Given this list of marker genes TFB2M, RNASEL, EIF4A3, RPS17, RPP40, RPL27, BMS1, EXOSC1, RPS24, NVL, MRM3, NPM3 (NCBI Gene Id 63295), RPP30, EXOSC6, PES1, RPS7, RPS6, UTP4, RBM34, GAR1, DROSHA, RPL11, DCAF13, IMP4, MPHOSPH10, NUDT16, DKC1, RPS25, NOC4L, POP4, PPAN, RPUSD4, TBL3, LAS1L, NOP2, NSA2, MRTO4, RPS8, FTSJ3 (NCBI Gene Id 54803), MPHOSPH6, DDX54, METTL5, DIMT1, METTL15, EIF6, NSUN3, NOL9, RPL7A, RPP25, SRFBP1, RPL35, REXO1, NOP58, GTF2H5, RCL1, METTL18, MAK16, ESF1, RPS14, RPP38, FBLL1, POP7, PIH1D1, SART1, PRKDC, NOP56, NOL10 (NCBI Gene Id 80085), RIOK2, TSR3, ERI1, NOP53, WDR43, GEMIN4, RIOK1, SPOUT1, WDR75, URB1, TRMT2B, UTP14A, DDX27, MRM1, SLX9, PIH1D2, WDR74, FRG1, EMG1, RPL7 (ribosomal protein L7), SUV39H1, TSR2 (TSR2 ribosome maturation factor), LYAR, RRP9, ZNHIT6, REXO5, WDR3, TRMT61B, RRP1B, DDX47, UTP3, PWP2, WDR12, XRN2, NOL7, DDX49 (NCBI Gene Id 54701), WDR18, EXOSC5, MTREX, EXOSC7, RRP36, UTP15, EXOSC2, NGDN, C1D, SDE2, BUD23 (NCBI Gene Id 84118), RRP1, EXOSC8, METTL25B, PAK1IP1, EXOSC10, RPUSD2, TFB1M, BRIX1, UTP25, DIS3, UTP18, RPS28, PWP1, KAT2B, KRI1, DDX17, UTP14C, RPS21, WDR36, ZCCHC4, DDX10, DDX51, METTL16, NOL6, MTERF4, DDX56, RRS1, UTP6, RRP8, NSUN4, RPS16, RRP7A, METTL15P1, UTP11, PDCD11, RRP7BP, DDX18, PA2G4, EBNA1BP2, USP36, RIOK3, IMP3, POP5, ABT1, RPUSD1, SNU13, RPF1, DDX21, EXOSC3, WDR46 (NCBI Gene Id 9277), EXOSC4, RPF2, TENT4B, CHD7, NOL8, NOP10, KRR1, NAF1, YTHDF2, RPL5, RPS19, RPL7L1, AK6, FBL, FCF1, CDKN2A, ISG20, RPL35A, UTP23, SBDS, WBP11, NAT10, PELP1, REXO1L1P, SIRT7, NOLC1, NOP9, DHX37, NOB1, WDR55, HEATR1, RPL26, NHP2, LSM6, RRP15, YBEY, EXOSC9, MYG1, BOP1, RPL14, RPS15, ERCC2, MRM2, RPS27, UTP20, FDXACB1, NSUN5, NOL11, PIN4, NOP14, TSR1 (NCBI Gene Id 55720), REXO4, ZNHIT3, DDX52, GTPBP4, BYSL, TRMT112, RBFA, here is a description of the gene set: Human Gene Set: GOBP_RRNA_PROCESSING species: Homo sapiens Any process involved in the conversion of a primary ribosomal RNA (rRNA) transcript into one or more mature rRNA molecules.